The following is a description of a gene set: Genes negatively differentially expressed in cell type: CD4+ T cell upon treatment with cytokine: IL-2 in mouse lymph nodes in vivo. Mouse Gene Set: CUI_T_CELL_CD4_IL2_RESPONSE_DN Cytokines mediate cell-cell communication in the immune system and represent important therapeutic targets. A myriad of studies have highlighted their central role in immune function, yet we lack a global view of the cellular responses of each immune cell type to each cytokine. To address this gap, the authors created the Immune Dictionary, a compendium of single-cell transcriptomic profiles of more than 17 immune cell types in response to each of 86 cytokines (>1,400 cytokine-cell type combinations) in mouse lymph nodes in vivo. A cytokine-centric view of the dictionary revealed that most cytokines induce highly cell-type-specific responses. For example, the inflammatory cytokine interleukin-1β induces distinct gene programmes in almost every cell type. A cell-type-centric view of the dictionary identified more than 66 cytokine-driven cellular polarization states across immune cell types, including previously uncharacterized states such as an interleukin-18-induced polyfunctional natural killer cell state. from publication Cui A, Huang T, Li S, Ma A, Pérez JL, Sander C, Keskin DB, Wu CJ, Fraenkel E, Hacohen N (PMID 38057668) species: Mus musculus, and this is the list of marker genes: Btg2 (NCBI Gene Id 98237), Jun, Tsc22d3, Ddit4, Cdkn1b, Klf2